The following is a description of a gene set: Human Gene Set: GOBP_REGULATION_OF_TYPE_2_IMMUNE_RESPONSE Any process that modulates the frequency, rate, or extent of a type 2 immune response. studied in species Homo sapiens, and this is the list of marker genes: RSAD2, IFNL1, XCL1, PRKCZ, IL6, ECM1, ANXA1, IL18, TBX21, ASCL2, IL27RA, DENND1B, ARG1, ARG2, CD74, STAT6, IL4, TNFSF4, IFNB1, IDO1, BCL6, IFNA2, HLX, SOCS5, CD86, NOD2, CCR2, NLRP3, IL33, CD81, GATA3, NDFIP1, IL4R (interleukin 4 receptor), RARA